The following is a description of a gene set: studied in species Mus musculus The chemical reactions and pathways resulting in the breakdown of a short-chain fatty acid. A short-chain fatty acid has an aliphatic tail containing fewer than 6 carbons. Mouse Gene Set: GOBP_SHORT_CHAIN_FATTY_ACID_CATABOLIC_PROCESS, and this is the list of marker genes: Ces1d, Pck2, Pck1, Ces1f (NCBI Gene Id 234564), Phyh, Acads